The following is a description of a gene set: studied in species Mus musculus Mouse Gene Set: GOBP_T_CELL_RECEPTOR_SIGNALING_PATHWAY The series of molecular signals initiated by the cross-linking of an antigen receptor on a T cell., and this is the list of marker genes: Ripk2 (receptor (TNFRSF)-interacting serine-threonine kinase 2), Sla2, Phpt1, Skint4, Lat, Usp9x, Icosl, Card11, Nck1, Btn2a2, Rab29, Themis3, Trat1, Ptpn2, Abl1, Traf6 (NCBI Gene Id 99098), Prkd2, Ceacam1, Ikbkg, Crkl, Vtcn1, Ube2n, Ubash3a, Lilrb4b, Rc3h2, Btnl2, Sh2d1a (NCBI Gene Id 279676), Skint10, Skint8, Sppl3, Ptpn22, Trav7-2, Pde4b (NCBI Gene Id 97194), Dennd1b, Gata3, Fyb1, Ada, Btnl6, Cd3e, Skint7, Bcl10, Dgkz, Skint11, Cacnb4, Mapk1, Bcl2a1d, Ezr, Stoml2, Mog, Btnl9, Ermap, Btk, Fyb2, Ptpn6, Lipa, Themis2, Rftn1, Lgals3, Slc39a6, Pvrig, Nfkbiz (NCBI Gene Id 80859), Rbck1, Prnp, Malt1, Btrc, Skint5, Rnf31, Cd226, Foxp3, Elf1, Usp46, Btnl12, Tnfrsf21, Nfkbid (NCBI Gene Id 243910), Shb, Usp12, Rps3, Skint3, Ctla4, Nectin2, Hras, Dusp22, Zc3h12a, Tec, Pawr, Zfp683, Themis, Dusp3, Cd8b1, Cd300a, Skap1, Cd247, Tespa1, Lcp2 (NCBI Gene Id 16822), Wnk1, Fosl2, Itpripl1, Btn1a1, Kcnn4, Carmil2, Cd28, Plcg2, Ubr2, Eif2b3, Clec2i, Eif2b5, Plcg1, Txk, Thy1, Skint9, Ptprj, Cd2ap, Rc3h1, Skint2, Cacnb3, Pde4d, Khdrbs1, Eif2b4, Skint6 (NCBI Gene Id 230622), Btnl4, Lime1, Stk11, Laptm5, Cd276, Nras, Lilrb4a, Lck, Btnl10, Fcho1, Rela, Psen1, Fyn, Cblb, Itk, Eif2b1, Pram1, Cd160, Cd81, Cyld, Ptprc, Btnl1, Skint1, Eif2b2, Ccr7, Zap70, Psen2, Cd8a, Ifng, Braf